The following is a description of a gene set: Mouse Gene Set: GOBP_THYMOCYTE_MIGRATION studied in species Mus musculus The movement of a thymocyte through distinct intrathymic niches (e.g. medulla, cortex), where it receives a unique set of developmental cues required for T-cell development., and this is the list of marker genes: Adam8, Ccr7, Xcl1, Ccr6, Ccl20, Coro1a, Aire, Ccr2